The following is a description of a gene set: from publication Chen X, Barozzi I, Termanini A, Prosperini E, Recchiuti A, Dalli J, Mietton F, Matteoli G, Hiebert S, Natoli G (PMID 22802645) Pan-Hdac inhibitors (HDACi) are endowed with a potent anti-inflammatory activity, but the relative role of each of the eleven Hdac proteins sensitive to HDACi to the inflammatory gene expression program is unknown. Using an integrated genomic approach we found that Hdac3-deficient macrophages are unable to activate almost half of the inflammatory gene expression program when stimulated with lipopolysaccharide (LPS). A large part of the activation defect is due to loss of basal and LPS-inducible expression of IFNb, which in basal cells maintains Stat1 protein levels, and after stimulation acts in an autocrine/paracrine manner to promote a secondary wave of Stat1-dependent gene expression. We show that loss of Hdac3-mediated repression of nuclear receptors leads to hyperacetylation of thousands of genomic sites and associated gene derepression. The upregulation of the constitutively expressed prostaglandin endoperoxide synthase, Ptgs1 (Cox-1), has a causative role in the phenotype, since its chemical inhibition reverts the Ifnb activation defect. These data may have relevance for the use of selective Hdac inhibitors as anti-inflammatory agents. Human Gene Set: GSE33162_HDAC3_KO_VS_HDAC3_KO_4H_LPS_STIM_MACROPHAGE_UP studied in species Homo sapiens Genes up-regulated in macrophages with knockout of HDAC3 after LPS treatment: heterozygous versus homozygous., and this is the list of marker genes: GPX2, CNR2 (NCBI Gene Id 1269), ZFYVE19 (zinc finger FYVE-type containing 19), ATL2, APPL1, SLC25A26, RCBTB1, ZNF622, REPS1, DHX40, IL18R1, PPP1R2P1, IRX1 (iroquois homeobox 1), BAG1, USP53, CHMP4B, CDT1, BTG2, SLC39A1, SYAP1, GFUS, NEK9, TDP2, DAZAP1, CNOT2, NAA38, RAB7A, HNRNPC, CNTD1, PPP4R1 (protein phosphatase 4 regulatory subunit 1), CRKL, KBTBD2, FKBPL, APPBP2, THAP7, BMI1, KAT6A, PMS2, TPRKB, SERP1, HNRNPD, KDM6A, UPF3B, OTULIN, TP53BP1, GOLGA5, LAMTOR1, RPIA, HYOU1, TM9SF2, SORL1, SEMA4B, SNAPC3, FBXO45, CGGBP1, INPP5D, GSK3B, CRIM1, ATP6AP1, TAF8, AIP, ARL8B (ADP ribosylation factor like GTPase 8B), MYCBP2, FRYL, PSMD14, KIF16B, FBXW7, PDPK1, BABAM1, ARG1, TBC1D14, SART1, DDX21, MAPK6, SP1, RAB22A, ANKRD17, SNX20, ZBTB44, SLX9, FHIP1B, CCR2, SMARCA5, LIN7C, NOTCH2, CMTM6, EIF4B, ATG12, RNF185, GNB1, PITPNM1, SRGAP1, NFATC2IP, MCM7, STK11, NUFIP1, RNF2, FBXL3, USP7, SPSB3, MDFIC, SH3GLB1, ARFGEF1, DIPK2A, MYO9B, TTC27, ATF1, WTAP, CAB39, FOXO3, SLFN12L, PUM2 (pumilio RNA binding family member 2), SNX18, OSBPL11, IMPDH2, CLTC (NCBI Gene Id 9511), ELK4, RBM15, SERTAD2, GTF3C4, DICER1, NIFK (nucleolar protein interacting with the FHA domain of MKI67), FAM117B, S100A6, NSMCE4A, FASLG, RSRC2, CCNT2, SOS2 (SOS Ras/Rho guanine nucleotide exchange factor 2), ZEB1, SELENOT, SIN3A, C5orf15, ATP6V1E1, SNX6, RLIM, HARS2, STX7, ZNF410, ZSCAN26, MTRES1, RBM42 (NCBI Gene Id 79171), YTHDF1, NSUN6, THAP12, GPBP1 (GC-rich promoter binding protein 1), DUSP16, PRPF39, VPS16, CLK4, FOXJ3 (forkhead box J3), PTGER4, SUPT20H, RNF11 (ring finger protein 11), CDK5RAP1, TRPS1, RNF111, NUMB, SPRTN, TRIM25, MLXIP, BOLA1, WASHC2A, NFKBIA, STRN, KXD1, RHEBL1, TBL1XR1, MICOS10, B4GALT7, CSE1L, EEIG1, BIRC6, ZPR1, RAB3IP, CDK11B, CNDP2 (NCBI Gene Id 55748), MRPS18B, HEATR6, RASSF5, NRDC, GTPBP4, KDM5B, SAFB, VPS11, ZNF292, UBR1, EEF1G, SEC61G, HEXA, DIS3, DNAJC8, QRICH1, WWP1, TADA1, GTF2H4, PIP4K2A, DNAJC4, KTN1, ZBTB17